Given this list of marker genes ZNF274, MMACHC, USP47, NDUFB6, UBAP2L, MAP3K11, PGAM1, MAN2A1, RPL7L1, UBXN8, HDGF (heparin binding growth factor), SNRPD3 (NCBI Gene Id 6634), UBE2D3, B4GALT7, TTL, CLCF1, PILRA, ACSL5, CYB5A, PRKAB1, KCNQ5, TJAP1, FURIN, NUMB, MFSD5, DERL2, GDPD1, FGF23 (NCBI Gene Id 8074), IYD, PAIP1, VPS13C, PDE8A, EMC7, DVL2, DCBLD2, TMEM165, CLCN5, SERPINE1, PGRMC1, DUSP2, SSTR3, SLC35D1, ACYP1, TLR8, PALS1, ZNF565, MYF6, USP39, TUFT1, FAM98A, TNFRSF1B, AMFR, RASGRP1 (NCBI Gene Id 10125), IPO4, FGD3, SLC25A25 (NCBI Gene Id 114789), FHIP2A, TNFAIP3, RNF44, SUPV3L1, FIGN, EPB41L5, SLC4A2, BLNK, TLR2, PDCL, IFITM10, SLC3A2, TMED7, GNG2, COL26A1, ROM1, NUCB1, AAMP, GPNMB, ALPK2, RANBP3, PPBP, NCSTN, DNAJC11, MAFF, RC3H2 (ring finger and CCCH-type domains 2), DNAJB11, FERMT2, ADORA2A, SYT17, CCT8, PHYKPL, PSPC1, H2BC5, RAB10, RAB2A, CMTM3, STARD4, BTF3L4, NOP10, UBXN2A, RHOA (NCBI Gene Id 387), WDR75, PPT2, CLCN1, OVOL2, OLR1, SQSTM1 (NCBI Gene Id 94002), IL36A, UBE2S, APPBP2, PKP2, PCBP4, RRP7A, ACLY, PDF, RDH10, AGO2, MEPCE, APP, TPP2, NADK, TRMT2A, TBPL1, SLC30A5, EEF1E1, STAM, KCNA3, UBE2G1, CAD, EDRF1, ZNF764, ZNF598, RELA, TFB2M, DNAJC21 (DnaJ heat shock protein family (Hsp40) member C21), TWIST1, TTC7B, RGS17, SACM1L, RBM15B, WDR6, SLC25A30, VTI1B, CABLES2, TOR4A, RUSC2, CREBZF, UBE4A, DNAJB6, NCK1, MYBPH, SIGLEC7, ID3, DHX40, ZNF426, BRAF, ARMCX3, GAS7, TPBG, KLF15, ABCC1, IRF3, HBS1L, MSC, PRDM1, RNF157, ZMYND10, CSNK2A2, SLC25A33, VPS4B, ERLEC1, ZBTB18, CDKN2B, PCNX1, MED10, EIF2B5 (eukaryotic translation initiation factor 2B subunit epsilon), LRRC42, COX6A1, LENG1, EIF2S3, CDC42SE2, GPC1, POFUT2, SLC41A1, MTFMT, LRRC59, PPTC7, CYFIP2, MYO5B, RCL1, NUP160, APBB2, ETV1, C18orf32 (chromosome 18 open reading frame 32), ATP6V1B1, TMEM120B, LATS2, TMX1, PTPRJ, SMIM7 (NCBI Gene Id 79086), FLVCR2, BRD8, ATF2, here is a description of the gene set: mouse primary BMDCs were stimulated with tlr ligands and gene expression changes were profiled on Affymetrix arrays studied in species Homo sapiens from publication Amit I, Garber M, Chevrier N, Leite AP, Donner Y, Eisenhaure T, Guttman M, Grenier JK, Li W, Zuk O, Schubert LA, Birditt B, Shay T, Goren A, Zhang X, Smith Z, Deering R, McDonald RC, Cabili M, Bernstein BE, Rinn JL, Meissner A, Root DE, Hacohen N, Regev A (PMID 19729616) Human Gene Set: GSE17721_POLYIC_VS_GARDIQUIMOD_4H_BMDC_DN Genes down-regulated in comparison of dendritic cells (DC) stimulated with poly(I:C) (TLR3 agonist) at 4 h versus DC cells stimulated with Gardiquimod (TLR7 agonist) at 4 h.